Given this list of marker genes COL5A2, CUX2, NTM, MYH1, XIST, PCDHGA1, FRMD4A, PLAU, OXTR (NCBI Gene Id 5021), CYP2C18, IGF1R, ATP2B4, MME, CATSPERB, PIEZO1, MGP, THBS1, DES (NCBI Gene Id 497658), COL6A1, MIR3648-1, KCNK3, FN1, COL11A1 (collagen type XI alpha 1 chain), COL1A1, PDLIM7, MICAL2 (microtubule associated monooxygenase, calponin and LIM domain containing 2), HSD11B2, PECAM1, MMP2, NOTCH2NLA, L1CAM, SPON2, MYL9, NEFH, DST, CSTA, ARHGDIA, STAR, INHBA, CLIC4, PDE12, TNFSF10 (NCBI Gene Id 8743), LOXL2, IGFBP2, PCDHGC3, OGT, IGLL1, IGFBP5, IGFBP3, ABCC6, PLEC, COX7A1, COL16A1, HIPK2, CHRNE, COL8A2, PRRC2A, NOX3, AKAP9, COL1A2, CCND1, BDNF, here is a description of the gene set: from publication Wilcox CB, Feddes GO, Willett-Brozick JE, Hsu LC, DeLoia JA, Baysal BE (PMID 18070364) BACKGROUND: Ovarian cancer (OvCa) most often derives from ovarian surface epithelial (OSE) cells. Several lines of evidence strongly suggest that increased exposure to progesterone (P4) protects women against developing OvCa. However, the underlying mechanisms of this protection are incompletely understood. METHODS: To determine downstream gene targets of P4, we established short term in vitro cultures of non-neoplastic OSE cells from six subjects, exposed the cells to P4 (10-6 M) for five days and performed transcriptional profiling with oligonucleotide microarrays containing over 22,000 transcripts. RESULTS: We identified concordant but modest gene expression changes in cholesterol/lipid homeostasis genes in three of six samples (responders), whereas the other three samples (non-responders) showed no expressional response to P4. The most up-regulated gene was TMEM97 which encodes a transmembrane protein of unknown function (MAC30). Analyses of outlier transcripts, whose expression levels changed most significantly upon P4 exposure, uncovered coordinate up-regulation of 14 cholesterol biosynthesis enzymes, insulin-induced gene 1, low density lipoprotein receptor, ABCG1, endothelial lipase, stearoyl- CoA and fatty acid desaturases, long-chain fatty-acyl elongase, and down-regulation of steroidogenic acute regulatory protein and ABCC6. Highly correlated tissue-specific expression patterns of TMEM97 and the cholesterol biosynthesis genes were confirmed by analysis of the GNF Atlas 2 universal gene expression database. Real-time quantitative RT-PCR analyses revealed 2.4-fold suppression of the TMEM97 gene expression in short-term cultures of OvCa relative to the normal OSE cells. CONCLUSION: These findings suggest that a co-regulated transcript network of cholesterol/lipid homeostasis genes and TMEM97 are downstream targets of P4 in normal OSE cells and that TMEM97 plays a role in cholesterol and lipid metabolism. The P4-induced alterations in cholesterol and lipid metabolism in OSE cells might play a role in conferring protection against OvCa. Human Gene Set: WILCOX_RESPONSE_TO_PROGESTERONE_DN Genes down-regulated in primary cultures of ovarian surface epithlium cells exposed to progesterone for 5 days. species: Homo sapiens